The following is a description of a gene set: Genes containing one or more binding sites for (ZNF766) in their promoter regions (TSS -1000,+100 bp) as identified by GTRD version 20.06 ChIP-seq harmonization. from publication Yevshin I, Sharipov R, Kolmykov S, Kondrakhin Y, Kolpakov F (PMID 30445619) Human Gene Set: ZNF766_TARGET_GENES studied in species Homo sapiens, and this is the list of marker genes: CAP1, CHCHD1, MIDN (NCBI Gene Id 94034), KCTD10, TPGS1 (tubulin polyglutamylase complex subunit 1), TSPAN7, SLC25A11, KDM7A-DT, RGS20, TMEM11, PGBD5, SLC9A3-AS1, MRFAP1, RALGPS2, ANKS6, RPP40, SYT3, ADAM9, EFNA3, IFT25, TJP3, USP6NL, ZMYND8, CHRNB1, SLC39A3, MMS19, TPH2, FBXL19, TMIGD3, TOMM40L, NDUFB2, RBBP5, LINC01732, CPED1, LINC01300, LIFR, SLC39A11, LIFR-AS1, SLC14A1, MARCHF4, RNU12, UBE2E2, HLCS-AS1, ALG6, MLH3, SFMBT1 (Scm like with four mbt domains 1), CAPG, LLGL2, ENSG00000260592 (NCBI Gene Id 124903659), PDE3B, MED15, ZGPAT, STK25, TRMT44, OSBP2, TMEM145, ERH, PXT1, WDR1, AIG1, DMBX1, CCDC88A, NORAD, DYDC2, ALMS1, PXN, ZBTB17, SCG2, GPANK1, METTL3 (methyltransferase 3, N6-adenosine-methyltransferase complex catalytic subunit), ZNF436-AS1, KLHDC8B, SMARCAD1-DT, BMAL1, SPINK4 (serine peptidase inhibitor Kazal type 4), TTC13, MAML3, PAPSS1, SNHG32, EOGT, VOPP1, APBB1, SH3BP5L, UCA1, KPTN, UTP11, GRK3 (G protein-coupled receptor kinase 3), PTBP3, HEPH, EHD1, ANTXR2, BIRC5, DUSP28, SBDSP1, UBE3C, STXBP5, ING3, CITED2, ERMAP, KRTAP10-4, TUFT1, CARMIL2, USF2, PPP1R12B, KRT18P67, YJU2, ENSG00000246465, THADA, TSC22D1, EML6, SMARCA4, HTR1A, CDK8, RPL36AP19, C19orf44, UBXN4, CCDC90B-AS1, HSPA13, XKR9, MPI, PACS2, NEDD4, ACTR3B, CENPV, ENSG00000240687, MEF2C-AS1, IFI27 (NCBI Gene Id 3429), LINC01932, MEIS2, AMMECR1, NF2, INVS, MIR3124, TTLL4, TRMT5, RPS13, CENPF, MEF2C, ZNF484, PDCD2, FAM124B, PLEKHF2, WARS2-AS1, ELOC, DNAJC17 (DnaJ heat shock protein family (Hsp40) member C17), ZNF221, THAP2, IFI16, CCDC71, ZSCAN22 (zinc finger and SCAN domain containing 22), ARID4A, ATXN7, VTRNA1-1, KDM7A, TH2LCRR, PDE4C, SMARCAD1, GNB4, KBTBD7, FBXO17, UNC13A, SAE1, CHAC1, EPS15-AS1, MIR4435-2, APOL3, DUX4L27, ASAP3, TSNAXIP1, RAB7A, NSMCE1-DT, SVOP, C11orf21, LACTB2, VAMP7, NAPA, NEAT1, USP48, TRIM69, TMEM245, TMEM181, MAPK8IP1, GUSB, RNU6-218P, RNU4-73P, ZFP91-CNTF, MINDY2-DT, CHCHD2, TFEB, IGF1, CAST, ESCO2, MYOM3, SENP8, MALSU1, PRR14, PRKCSH (NCBI Gene Id 5589), S100P, PFDN6, NUP54, B4GAT1, CCDC163, SNX5, B9D2, UBE2V1P4, ZNF529, SCNM1, WDR81, AUP1, LINC-PINT, RPS27, IL2RB, COMMD3-BMI1, H4C8, MAP4K3, RPLP0P2, SZRD1, DDX17, UBE2Q2, MIR4766, TNFRSF10A-AS1, ZNF585A, EPC1, SCRIB, FCRLA, WDPCP, ACP2, TCEANC2, MOSPD1, SFXN1 (NCBI Gene Id 94081), ADGRB3, FTO, STAG2, ZNF649, ALDH5A1, SHARPIN, FAF2, SRGAP3 (NCBI Gene Id 9901), QRICH1, IBA57, ZDHHC18, RPL7P25, IPO8, ZNF225-AS1, MRGBP, IL1RN, CCR7, UBXN2A, RPIA, ASXL2 (ASXL transcriptional regulator 2), ALB, CTSB, S100Z, EXOC6, NUDT13, GNL3L, IL18RAP, PLAU, CCDC137P1, BORCS7, MR1, SIGLEC6, IL23A (NCBI Gene Id 51561), G3BP2 (G3BP stress granule assembly factor 2), MIR378F, UBE2E3-DT, CLIC1, LINC00663, RPS21P8, SEC61A1, PRR13, ERI3, ASNSD1, TTC33 (NCBI Gene Id 23548), RELN (NCBI Gene Id 5649), ADIPOR1, CRADD, PRR5, LPXN, GNB1, PODXL2, ROPN1L (NCBI Gene Id 83853), MITF, SLC35B4, FAM117A, C1orf74, RIC8B, ZMYM4, SPRING1, LINC02777, CLUAP1 (NCBI Gene Id 79851), BTNL9, IFRD2, ZNF444, ERBIN-DT, SUMO3 (NCBI Gene Id 6612), SCAT2, B4GALT2, PI16, CCDC124 (coiled-coil domain containing 124), NR1H3 (nuclear receptor subfamily 1 group H member 3), GPAT4, PAAF1, ATG4B, COPS7B, CPLX3, PEAK1, TRAPPC10, OTUD7A, C2CD2L, ATF7IP2, EVI2B (ecotropic viral integration site 2B), TOR1A, DOK2, SLC2A4RG, AHCTF1, CPSF1, OAZ1, CLPB, ZNF217, C2 (NCBI Gene Id 12263), HGD, PDCD10, MAD1L1, RN7SL519P, DUSP10, SQOR, NOP53, C19orf38, TM2D2, MTSS1, MGAT1, BATF, MYO5B, MICOS13, PTCD3, LINC02683, HSPH1, AQP8, KMT2B, NOSIP, KBTBD6, PPFIA4, CFAP99, CCP110, AKR1C1, RNFT2 (ring finger protein, transmembrane 2), SCAMP4, VMP1, ZFYVE1, CALCRL-AS1, CBFA2T3 (NCBI Gene Id 863), SYNCRIP, IFT140, NUP43 (nucleoporin 43), RHOA, ANKMY1, ZNF674, COX6CP5, ZNF227, SBK1, MAT2A (NCBI Gene Id 4144), ATG4C, BCKDK, RPL36, TBC1D8B, ARRDC3, YEATS2, ZNF223, GDAP1, FAM193A, RNF167, ZNF341-AS1, GNB1-DT (GNB1 divergent transcript), HECTD2, SETD5, KRBA1, DHRSX, TMEM14B, CHD7, CYB5R4, NEUROD4, CHMP4B, MYB, ZNF586, RANGAP1, VRK1, WBP2, ADGRB3-DT, CALB1, ZNF345, BUB3, ZNF268, DNHD1, KHDC4, TMCC1, RERE, RBM25, CD80, CSRNP2, UBQLN4, DST, CRYM, MYOSLID-AS1, ARL6IP5, C10orf53, FAM222A, LINC02772, HAUS6, MPZL3, SULT1A2, SIGLEC27P, SPTAN1, ZNF688, C3orf86P, AP2M1, LINC00504, PGM2L1, PPP4R1L, ENSG00000230773, USP35, MRTFA, MIR4435-1, TPD52L1, IMPDH2, KAT7, OR4K17, ENSG00000232884, FBXL17, TMEM160, C1orf159, STMN3, SLC44A1, EPB42, IKZF2, SAP30, SHLD2 (shieldin complex subunit 2), LINC01433, IFRD1, STMP1, NOS3, PHF13, YIF1B, WBP1, SRCIN1, DGAT2, ENSG00000253574, TRIR, STAU2, PRMT3, PTBP1, ENSG00000232053, SFT2D2, SMPD2, ZNF821, RAB1A, LUCAT1, SLK, PIPOX, MAX, UPF1, LINC02252, CDC73, OTUD6B-AS1, FHL2, FCSK, CRTC2, ARV1, HM13, GNG4, ACTB, SHOC1 (NCBI Gene Id 158401), ARPC1A, REXO2 (NCBI Gene Id 51640), PTPRU, ENSG00000227245, DNALI1, TFR2, NAPEPLD, GPR146, NAGLU, AHSA2P, SDSL, FBXL3, SDE2, ZNF350, MADCAM1-AS1, EFCAB10, ENSG00000254718 (NCBI Gene Id 101927702), NUCB1-AS1, LINC00656, KCTD20, ACTR1A, LINC02928, CARD8-AS1, CTTNBP2, AHCYL2, TMEM70, ZNF432, ZNF56P, RCBTB2, KCNIP2, CALCOCO1, RPGRIP1L, MUTYH, CDYL, CSRP1-AS1, CCT8, BABAM1, NPEPPSP1, ENSG00000237346, PLSCR2, FASN, RNF145, CSRP1, RNA5SP60, LYL1, ANXA2, PCBP1-AS1 (NCBI Gene Id 652470), MAG, ENSG00000265845, WSB1, TCAM1P, HMGN2P34, NFKBIA, RIMKLB, CRAMP1, CNPY2, AKTIP, POLR2A, NAA38, MUS81, IGF1R, KCNB1, LNX1, PNPLA6, AP3B2, IGFL2-AS1, ZDHHC5, NFE2L1, PDE6D, RO60, MACC1, ADAT3, MLLT10, CHIC2, RPS3P7, TLK1P1, ERVK3-1, TMPRSS12, ARMH4, CLIC2, PRKCA, GLRA1, AKAIN1, BTN3A2, TM9SF4, RSRC2 (arginine and serine rich coiled-coil 2), ZNF181, TMED1, THRAP3, TMCO1 (transmembrane and coiled-coil domains 1), EVL, GPT2, KCNAB1, LINC01602, DUS3L, LUC7L, CIC, PNKD, PROSER2, KLK2, TP53BP2, SLC38A2, INTS6-AS1, PHF12, RHOBTB3, KCTD21, NEIL3, MIR5696, ARHGAP25, MANBAL, CD53, LINC01962 (long intergenic non-protein coding RNA 1962), LTA4H, PISD, LRRN4 (leucine rich repeat neuronal 4), ZNF37BP, AREG, SNORD3J (small nucleolar RNA, C/D box 3J), RAB6A, RUNDC3A, C1orf174, C17orf58, IMPACT, GPRC5C, LNCTSI, TACR2, SH2B1, RNF187, UPF3A, AP2A2, ARID4B, MIR1183, LINC02363, GLUD1, DNAJA3, PDS5B, FLJ46284 (NCBI Gene Id 441369), PPP6R1, VAPA, HMBS, CPNE2, LRRC41, SELENOH, RALGDS, LAMA4, VPS35L, CTDP1, GSPT1, PCGF5, C10orf95-AS1, SMAP1, SEPHS2P1, TAFA2, ZNF175, RN7SL824P, APOO, CEP164, GATAD2A, KRT73-AS1 (KRT73 antisense RNA 1), TMCO1-AS1, CCDC174, LAMTOR2, MKKS, CCAR1, ZNF37A, TMEM59, ZNF230, ANKRD65, SCG3, SSH1, DOLPP1, LINC01586, ZNF84-DT, P2RX6, SYNGR1, RABGAP1L, WARS1, MIDEAS, MPP2, DNM1L, TANC1, LINC03023, MAD2L1BP, HSD11B1L, NRDE2, RAB29, FGF13, XYLT2, MINDY2, SNHG5, GPBP1, TRAM2-AS1, EED, SAMD11, PTMA, FBXL16, RPS10-NUDT3, RN7SKP192, POM121, SYNJ1, RPS10 (NCBI Gene Id 6204), TULP2, STPG1, IQCH-AS1, AKAP8, RMC1, TFAP2A, CLCN3, CFAP107, PCSK6-AS1, SPEN, DMD, WNK1, CHFR, ARFRP1, MAPK8IP2, PRPF31, SNX10, TFPT, CDH23, GPKOW, YIPF6 (Yip1 domain family member 6), PTK2, ZNF415, TSC22D2, GTF2H4, GPR19, FAM193B, STC2, ABCA15P, ZFC3H1, UBE2E3, ADAMTSL4, GFUS, PROZ, IKBIP, PLA2G6, GAB2, FAM13A, SNHG11, DIAPH1 (NCBI Gene Id 1729), ODAD3, HEMGN, STAT5B, AMOTL1, HIKESHI, ZNF529-AS1, TNC, HHATL, SLC25A6, TM7SF3, PTP4A3, BICD2, SLC38A2-AS1, GMFG, OTUD6B, SNAPIN, MGME1, ATP5PF, CARINH, EHMT2, TBL1X, PSMA3-AS1 (PSMA3 antisense RNA 1), ATP2B4, IRF2BP2, PDE4A, B3GNT8, SMAD3, YAP1, SKIL, TMEM69, VDAC2, RN7SL371P, NEK6, RABGAP1L-DT, NUP205, LCORL, RPL23AP77, COMMD3, DEDD, C11orf58 (NCBI Gene Id 10944), MDH1, IFTAP, ENSG00000253775, ORMDL3, AMN1, SAMD9L, SOX6, LINC03126, TARBP2, GRM1, CDK5, RBBP4, C2orf92, LMNB2, MIR548AL, PANK4, RBM14, SRD5A3-AS1, ARHGEF12, MARCHF2, SUMO2, SLC38A6, TMCC1-DT, AKT1S1, XPO6, SCRT1, ATP13A1 (NCBI Gene Id 57130), FKBP8, TXNDC2, NFE2, ART3, RCAN1, ZC3H7A, FLYWCH1, WDR87, SCAF1, HNRNPH3, SCGN, GPER1, BARHL1, AIM2, N4BP2L2, RNU4-18P, MATN1, CACNA1D, ECHDC2, TMCC2, BCAT1, POT1-AS1, FAM193B-DT, LHFPL4, RNU6-169P, ENY2, AP1S2, TRIM7-AS2, TTBK1, PTPRVP, SFSWAP, TMBIM1, CCDC137, GGPS1, NIFKP7, LEPROTL1 (NCBI Gene Id 23484), CABIN1, TPBGL-AS1, GTF2IRD1, CPLX2, TRIM29, AKIRIN2, FYCO1, AP2S1, ZNF605, UROS, MMACHC, CAMP, IBA57-DT, ACVR1B, TNFAIP1 (TNF alpha induced protein 1), TCERG1, DCK, TMEM11-DT, CLEC16A, OXSR1, ZCCHC8, MIAT, ILF3, MIR7-3, RCHY1, PAGE5, SIRT2, ZNF230-DT (ZNF230 divergent transcript), LASP1, LINC01287, FAM168B, LHFPL5, IL1R1, PHB1 (prohibitin 1), GTPBP2, PTPRN, SNORD48, PPP1R15A, TK2, PRKACA, TMTC1, ZNF84, ARHGAP5-AS1, ARL4A, UQCRH, RANBP10, MIF4GD-DT, ZBTB8OS, PCK1, LIG1, RYK, TENT2, PA2G4, TSSC4, STRN3, VTN, ENSG00000227706, OGDHL, USP31, LNCATV, RIN3, NUCB1, RNY3P11, PAFAH2, UBL4A, TRIM5, SLC9A3-OT1, SOCS2, RN7SKP249, VOPP1-DT, GFPT2, WDR25, MAF1, RUNDC3A-AS1, NTAN1, ENOX2 (NCBI Gene Id 95974), MIER1, XIST, ASB8, DGAT1, LINC03046, CPE, RNU1-108P (RNA, U1 small nuclear 108, pseudogene), ZNF436, MIF4GD, NOXO1, WDR46, VPS29, NFASC, NPRL2, TRPM7, MAK16, SEC24C, NDUFAB1, GFOD1, BMERB1, RPS12P23, ALG1L13P, TRIM67, RALBP1, EPC2, GRAMD4, ENSG00000253887, ZFYVE19, GAPVD1, ACTL6B, FN3K, DIAPH1-AS1, SETMAR, NPPB, ARHGAP5, KANSL3, APAF1, LARS1, RFPL1S, ZBED6, CELF6, FZD3, LINC01816, BANP, PABPN1, CSNK2B, KIF15, GTF2I, EIF4H, COX15, AAMP, RPS4XP16, LYSMD1, CCDC90B, CUTC, IFT20, DYNC2I2, VARS2, ST3GAL2, PACS1, HTRA2, LINC02354, LYPLA1, ISCA2P1, NFKBIB, C15orf61, RPRD1B, ILF3-DT, SOX12, UBR2, LINC01169, PEX26 (peroxisomal biogenesis factor 26), ZFYVE28, AKR1E2, TNPO2, CLSTN1, TRMT12, LSM10, PPIL6, TOE1, RN7SKP237, CBX7, TMTC3, SIPA1L3, TCTA, FOXP1, S100A11, KBTBD6-DT, UBR3, SLMAP (NCBI Gene Id 7871), SLC26A4, CHD4 (NCBI Gene Id 1108), CXCR3, CENPT, GATB, OTUD4 (NCBI Gene Id 95936), PTAR1, PMFBP1, SYMPK, TIMM21, ZNF776, CPOX, GFER, PCSK6, RPAP1, VLDLR-AS1, ENSG00000266976, ZNF614, CFL1, TBC1D17, EYA3 (EYA transcriptional coactivator and phosphatase 3), EML2, SH2D6, PPRC1, FYB1 (NCBI Gene Id 55458), TAL1, CREM, ZNF337, STK40, SMIM13, POR, RNF149, UBAC1, CP, LYN, MIR4729, DHRS3, PPM1A (protein phosphatase, Mg2+/Mn2+ dependent 1A), ABCF3, KIAA1143, ZNF644, KIF2C, FOXA3, AFAP1-AS1, CLTC, ZNF225, SNX19, PFDN1P2, USP20, BANCR, TMEM115, STAP2, ANKDD1B (ankyrin repeat and death domain containing 1B), TTC1, NRSN2-AS1, MADCAM1, PGP, NKAIN1, PRKAG1, MIR7-3HG, TIAL1, INTS6, GPN3, EPB41L5, MFAP3L, SLC45A4, ADORA3, IL23R, NDUFV2-AS1, UNC45A, NUTF2, DCTN2 (NCBI Gene Id 1640), COX7C, MTCP1, OPLAH, ZC3H11A, LARP1, LINC03108, LINC01521, STXBP5-AS1, HSD17B11, MRPL24, EPC1-AS1, ZNF207, LINC01898, FAM83A, VILL, B4GAT1-DT, ZNF615, WWP1, ARPP19, KRTAP2-4, POLDIP3, SNAP25-AS1, PPP1R13L, NR1I2, LRIF1, SEC11C, DGCR8, ZSWIM9, TNS1, SAP30-DT, POLR1G, MELK, NFIX, ATXN7L3, HERC1, CASS4, TBX6, ZNF862, TSSK3, ERP44, MAN2A2, CYB5D1 (NCBI Gene Id 124637), RXRA, CALR3, BOD1, NOP14, BFSP2-AS1, MPND, TCEA2, ZNF32, GLB1L2, UBE2O, H6PD, SERPINI1, TXNDC15, LINC02476, DUS1L (NCBI Gene Id 64118), CCDC12, SLC16A1, PRPSAP1, PRRT2, FBXO15, NPEPPS, VPS72, CISH, SERBP1, PEX14, HBD, MYO9A, DNAJB2, PATZ1, DUSP4, CTDSPL2-DT, GAS6-AS1, GPR158, SH3GL1, PLCG2, SLC4A2, TSSC2, ZNF140, SLC25A12, ATG10, NICN1, DRC12 (NCBI Gene Id 283152), STRIP1, PSMA1, DYNC1I2, USP32, SLX4IP, GPBP1L1 (NCBI Gene Id 60313), FASTKD1, NPL, CORO1A, THAP4, POLR3H, UBE2E2-DT, THUMPD2, ZNF81, KLHL21, GCSAML, TBC1D4, SLC48A1, PPP1R12C, CA1, HTR5A, ZFP37, B3GNT5, ENSG00000268460, FARSA, CDCA3, MANEALP1, COX7A2L, IKBKB-DT, GAREM2, GDPD5, MYCL, GP6, GALNT7, ZNF674-AS1, ANKRD12, ENSG00000228395, ENSG00000266401, ATP6V0A1, MTIF2, USF1, TRIT1, ZFP91, NUMA1, ZNF331, GIRGL, PPIAP16 (NCBI Gene Id 5488), SLC39A9, STAU1, MAP4K3-DT, LEMD2, KNSTRN, PACSIN2, CTDSPL2 (NCBI Gene Id 51496), BTRC, HMG20A, LINC02412, LINC01683, ZRANB2-DT, CEP290, WDR24, DHX40, RAD9B, NUDCD1, KLC1, ACTR3, CYB561D2, VTRNA1-3, ENSG00000253986, RAB27B, PADI4, CNOT1, VPS50, FNBP1, NSMAF, DIP2A, CCZ1P1, PKD1L2, GRK4 (NCBI Gene Id 2868), UBA5, SMPD3, DESI1, ACTG1, UCP2, GRK3-AS1, DENND1A (NCBI Gene Id 79878), DDX23, DFFA, CHCHD2P1, REDIC1, PEMT